The following is a description of a gene set: The process in which T cells that express T cell receptors that are restricted by self MHC protein complexes and tolerant to self antigens are selected for further maturation. Human Gene Set: GOBP_T_CELL_SELECTION studied in species Homo sapiens, and this is the list of marker genes: SYK, CD4, BCL2, ATG5, PTPN2, IL6ST, FOXP3, JAG2, BATF, IL15 (interleukin 15), EP300, BRD2 (NCBI Gene Id 9803), CARD11, STAT6, SLAMF6, STK11, ITPKB, SRF, FOXN1, DOCK2, PTPRC, CD69, CYLD, CD1D, STAT3, CD28, LOXL3, LY9, IL12B, JAK3, RHOA, IL12RB1, CD74, TNFSF18, MTOR (NCBI Gene Id 2476), GLI3, CTSL, SHH, AIRE, ZAP70, IL6R, STAT5A, IL23A, SPN, BRAF, NFATC3, IL23R, CCR7, IL6, OPA1, BCL11B, ZFPM1, IRF4, SOCS3, TOX, LGALS1, CD3E, CD3D, BRD4, GATA3, THEMIS, JAK1, CD3G, TBX21